The following is a description of a gene set: Mouse Gene Set: GOBP_METANEPHRIC_TUBULE_FORMATION studied in species Mus musculus The developmental process pertaining to the initial formation of a metanephric tubule., and this is the list of marker genes: Wnt4, Wnt9b, Pax2, Sox9, Pax8, Sox8